Given this list of marker genes CNOT6L, KLF3, FCGR2B, KATNB1 (katanin regulatory subunit B1), ATP2B1, ELOVL7, NSG2, SAMD3, CCND3 (NCBI Gene Id 896), EMB, AS3MT, FGF13, TXK (TXK tyrosine kinase), ADK, RNF32, FBXW7, ARHGAP26, HSD11B1, CD2AP, DPH5, CD44, LEF1, NEDD4L, ARL4C, TCF7, GZMM, PLEKHA6, BTLA, PRKCQ, GAS7, DOCK2, REXO2, PRUNE1, TSPAN2, ARHGAP5, ARID3B, S1PR1, F2RL2, GPR155, KLRG1, NRM, TIRAP, FRY, IL6R, RIPOR2, SFXN3, COBLL1, FAM53B (family with sequence similarity 53 member B), HDAC10, DAPL1, RACGAP1, SLC17A9, ITGAM, NAT10, ACTN1, CD9 (NCBI Gene Id 928), SH3BP5, PHF21A, B4GALT7, DGKA, TBC1D22B, RASA3, LANCL3, AGPAT3, FAS, DCP1B, CD247, DMRTA1, ELMO1, NFATC3 (nuclear factor of activated T cells 3), LAIR1, SLAMF6 (NCBI Gene Id 114836), RXRA, SLC25A27, ICAM2, FBXO28, PIK3R5, ETS1, CD7, RCSD1, SELL, KBTBD11, RAP1GAP2, VAV3, TLR1, TAGLN2, EOMES, CX3CR1, RASGRP2, CCR7, PPP1R14B, DYM, CENPT, TTC7B, CYRIA, DEF6, IL18RAP, FOXP1, PIGV, GPD1L, ST3GAL1, ECHDC1, SNX4, C19orf38, SMAD4 (SMAD family member 4), PLXNC1, TCF20, METTL27, SIKE1, CMAHP, IL27RA, B3GNT2, TNFAIP8L2, SCML4, FRYL, GNPTAB, VIPR1, AP1G2, ZSWIM6, RFX3, PDLIM1, CD84, PRKCB, QPRT (quinolinate phosphoribosyltransferase), TPM4, MDN1, MAPK11, GGT1, GRAMD4, IKBKE, ARHGAP1, ELK4, S1PR5, SLC11A2, HAAO, KLHL6, CYTH1, RNF138, CD55, PIK3IP1, CDC42SE1, ATP10D, EML3, GPR146 (G protein-coupled receptor 146), LRCH3, WDR4, PHYHD1, EPS15L1, USP28, MIR342, TRAF5, LPIN1, PIK3R1, IL18, ARL5C, NCK2, SCFD2, CYP17A1, PDE2A, NDUFA4, FRRS1, TNFAIP8L1, GRK6, SMPDL3B, BACH2, ITGA4, BIN2, IQGAP2, RAPGEF4, HS3ST3B1, TNFSF8, CDC14B, ZC3H12D, WWP1, SGMS1, AQP9 (aquaporin 9), ADD3, RNF144A, here is a description of the gene set: species: Homo sapiens This study aims at identifying genes that are NIK/NF-kappaB2 responsive in murine dendritic cells matured in vivo. from publication Lind EF, Ahonen CL, Wasiuk A, Kosaka Y, Becher B, Bennett KA, Noelle RJ (PMID 18566401) Human Gene Set: GSE7219_UNSTIM_VS_LPS_AND_ANTI_CD40_STIM_NIK_NFKB2_KO_DC_UP Genes up-regulated in dendritic cell NIK NFkB2-KO versus dendritic cell NIK NFkB2-KO LPS and anti-CD40 stimulated.